Given this list of marker genes UBQLN1, SEC11B, KAT2B, F3, PSMD3, COLEC11, USP14, PSMB4, DNAJB2, HSPB1, PRICKLE1, PSMA4, UBE3A (ubiquitin protein ligase E3A), PSMD11, SF3B3, SGF29, MBL2, PSMB9 (proteasome 20S subunit beta 9), IMMP2L, SEC11C, TADA1, ECPAS, PSMA5, SPG7, PSMD8, HTRA2, COLEC10, KAT2A, PSMB11, CASP9, VCP, PSMC5, ZFAND2A, TAF5, THBD, SPCS1, AFG3L2, PSMA3, TAF9, PSMB8, IDE, PSMC3, TAF6L, PIGU, PMPCB, PLAUR, TRRAP, PSMB5, PSMD7, PLAU, GPAA1, PIGK, PSMD2, ENY2, PSMF1, TAF10, PSMA7, PSMD5, RAD23B, PSMB2, PIGS, CAPNS2, ATXN7L3, SUPT20H, TAF5L (NCBI Gene Id 27097), PSMD9, PSME4, PSMC6, PSME2, SUPT20HL2, ZFAND2B, CASP2, FCN1 (ficolin 1), PSMB3, FAP, UBQLN4, CAPN2, CAPN1, PSMD4, PSME3, SF3B5, SUPT3H, PSME1, PSMB1, PSMA8, RAD23A, SUPT20HL1, PIDD1, PAAF1, TADA3, USP22, F7, PSMA1, TADA2B, SEM1, PSMB6, CFH, PSMC2, UBR1, SUPT7L, SEC11A, UCHL5, PSMD1, CRADD, PSMB7, SPCS3, UBE3C, TAF6, CAPNS1, PSMA6, PSMB10 (proteasome 20S subunit beta 10), PSMD12, TADA2A, ATXN7, PIGT, PSMC4, SPCS2, FCN3, PSMD14, IMMP1L (NCBI Gene Id 196294), FCN2, ADRM1, PSMC1, PSMA2, TXNL1, PSMD6, PSMD10, PMPCA, TAF12, PSMD13, here is a description of the gene set: Human Gene Set: GOCC_PEPTIDASE_COMPLEX A protein complex which is capable of peptidase activity. studied in species Homo sapiens